Given this list of marker genes GPX1, GPX4, PTGS2, ALOX15, ALOX15B, GPX2, here is a description of the gene set: studied in species Homo sapiens Human Gene Set: REACTOME_SYNTHESIS_OF_15_EICOSATETRAENOIC_ACID_DERIVATIVES Synthesis of 15-eicosatetraenoic acid derivatives